The following is a description of a gene set: The process in which a relatively unspecialized cell acquires the specialized structural and/or functional features of a cardiac fibroblast. A cardiac fibroblast is a connective tissue cell in the heart which secretes an extracellular matrix rich in collagen and other macromolecules. Human Gene Set: GOBP_CARDIAC_FIBROBLAST_CELL_DIFFERENTIATION species: Homo sapiens, and this is the list of marker genes: MIR21, INHBA, TGFBR3, SPRY1, PDCD4